The following is a description of a gene set: studied in species Mus musculus Mouse Gene Set: GOBP_NEGATIVE_REGULATION_OF_FEEDING_BEHAVIOR Any process that stops, prevents or reduces the frequency, rate or extent of feeding behavior., and this is the list of marker genes: Ins2, Npy2r, Napepld, Nmu, Npsr1, Retn, Ceacam2, Ins1, Insr, Ucn, Cck, Mc4r, Trh, Crhr1, Fto (NCBI Gene Id 26383), Lepr, Crhr2, Esr2, Ttc21b